The following is a description of a gene set: Mouse Gene Set: MIR_719 from publication Chen Y, Wang X (PMID 31504780) Genes predicted to be targets of miRBase v22 microRNA mmu_miR_719 in miRDB v6.0 with MirTarget v4 prediction scores > 80 (high confidence targets). species: Mus musculus, and this is the list of marker genes: Rims2, Amz1, Cadm3, Gpm6b, Cic